The following is a description of a gene set: Gastrointestinal inflammation species: Homo sapiens Human Gene Set: HP_GASTROINTESTINAL_INFLAMMATION Inflammation of the alimentary part of the gastrointestinal system., and this is the list of marker genes: IL10RA, CHD8, DKC1, LAMC2, NCF2, IFT74, GDNF, GPR35, INAVA, SLC2A10, IFT27, SEMA3D, GUCY2C, IVNS1ABP, BBS4, DOCK2, WDPCP, WIPF1, NOP10, ARPC1B, EDN3, ACADVL, SCAPER, BBIP1, TCF4, IKBKG, XIAP, COL17A1, TGFBR2, ELANE, NPHP1, GLRA1 (NCBI Gene Id 2741), FH, IL21, IRGM, SLC6A5, SKIC2, CARMIL2, SKIC3, HPS1, TGFB2, ELF4, IL10RB, TGFB1, ZAP70, TNFSF15, CIITA, NCF4, STAT3, FNIP1, SLC9A3, LAMA3, DCLRE1B, RET, BBS10, BBS9, IFT172, MST1, FCHO1, IL37, TTC8, STAT6, ARL6, BCL10, CYBC1, PIK3CG, MMP1 (matrix metallopeptidase 1), OPLAH, IL12RB1, MKKS, FCN3, CASP10 (NCBI Gene Id 843), BBS1, MEN1, IARS1, MASP2, TGFB3, SMAD3, PRF1, LYN, GPIHBP1, TRIM32, NFKBIA, GPHN, SPIB, RIPK1, ADAMTS2, NOD2, PI4KA, CTLA4, ZFX, CDKN1B, SHARPIN, DNASE2, SMO, DEF6, EDNRB, HLA-DRB1, PSMB10, ATP7A, LAMB3, SEMA4D, HLA-B, MAP3K7, POU2AF1, PSTPIP1, STXBP2, F13A1, MKS1, POLA1, MMEL1, STAT1, DOCK8, RTEL1, MYH11, TNPO3, FXN, CARD11, CARD10, SLC37A4, SYK, CARD8, FAS, IL6, NRTN, GLRB, ERBB3, PIGY, CEP290, COG6, STX11, PLCG2, STXBP1, RPL11, LMX1B, SREBF1, PTPN6, DOCK11, BBS12, BBS5, TTC7A, LZTFL1 (leucine zipper transcription factor like 1), BBS2, CEP19, PGM3, REL, TRAPPC11, PHGDH, LRBA, TNFAIP3, ABCD1, ABCB1, BACH2, NLRC4, MEFV, DSG1, JAK1, FERMT1, SCLT1, GRB10, F13B, FOXP3, RBCK1, COL7A1, SDCCAG8, UNC13D, IL12A, ECE1, IRF5, SEMA3C, CFAP418, FASLG, PIK3CD (phosphatidylinositol-4,5-bisphosphate 3-kinase catalytic subunit delta), WAS, ATAD1, ERBB2 (NCBI Gene Id 2064), BBS7, TGFBR1, PSPH, ADAMTSL2